The following is a description of a gene set: Abnormal type or counts of nucleated immune cells and acellular components in bronchoalveolar lavage (BAL) fluid. BAL us performed with a fiberoptic bronchoscope in the wedged position within a selected bronchopulmonary segment. BAL is commonly used to inform the differential diagnosis of interstitial lung disease or to monitor therapeutic interventions. studied in species Homo sapiens Human Gene Set: HP_ABNORMAL_BRONCHOALVEOLAR_LAVAGE_FLUID_MORPHOLOGY Abnormal bronchoalveolar lavage fluid morphology, and this is the list of marker genes: SFTPC, HLA-DRB1, CAPNS1, CSF2RA, SFTPB, ARPC5, SFTPA2, ABCA3, BTNL2, OAS1, CSF2RB, MARS1, NKX2-1, COPA, SLC7A7, MUC5B, SFTPA1, TERT